The following is a description of a gene set: Genes predicted to be targets of miRBase v22 microRNA mmu_miR_1970b_5p in miRDB v6.0 with MirTarget v4 prediction scores > 80 (high confidence targets). studied in species Mus musculus Mouse Gene Set: MIR_1970B_5P from publication Chen Y, Wang X (PMID 31504780), and this is the list of marker genes: Rnf214, Cuedc2, Nsd2, Celf4, Runx3 (runt related transcription factor 3), Fbxl17, Adam10, Smad1, Ano4, Ccnd1, Gnb4, Zfp263, Zfp950, Slc39a10, AI182371, Gas2l1, Emp1, Snrk, Prkg1, Tesk2, Larp4, Gprc5b, Sostdc1, Cpsf7, Prss57, Pcm1, Henmt1, Clock, Fbxw2, Rfx7, Abce1, Nfib, Ino80d, Qrich1, Fbxo30, Gucy2e, Rbm45, Arl4c, Esp18, Ppp3r1, Prpf4b, Tox3, Crbn, Mtus1, Mindy2, Gal, Ctsl, Ppp2r5e, Rap1a, Zfp62, Tmem26, Clec5a, Itga4, Avpr1a, Actmap, Magi3, Krtap19-9b, Mpdz, Snx10, Hikeshi, Akt3, Ugt8a, B2m, Serpina5, Zfp36l1, Amfr, Tm9sf3, Pid1, Zfp36l2, Prex2, Ncapg2, Ppp1r3c, Vmn1r235, Zfp37, Treml1, Vwc2, Terb2